Given this list of marker genes Cyp2d22, Cyp2f2, Cyp2a12, Cyp2a4, Cyp2e1, Cyp2c65, Cyp2s1, Cyp2c66, Cyp2a5, Cyp2b23, Cyp2a22, here is a description of the gene set: CYP2E1 reactions species: Mus musculus Mouse Gene Set: REACTOME_CYP2E1_REACTIONS